The following is a description of a gene set: Reactome Pathway: Free fatty acid receptors studied in species Homo sapiens Fatty acids are the ligands for a small family of G-protein-coupled receptors, the Free Fatty Acid receptors, and an unrelated receptor GPR120. <br><br>Free fatty acid receptor 1 (FFAR1/GPR40) is activated by both saturated and unsaturated medium to long-chain fatty acids while FFAR2 (GPR43) and FFAR3 (GPR41) are activated by short-chain fatty acids (carboxylates) with six or fewer carbon molecules. A fourth highly homologous receptor GPR42 is believed to be a pseudogene with intact open reading frame, but could be a functional gene in a significant fraction of the human population. <br><br>GPR120 is activated by long chain (C16-22) fatty acids. part of: Class A/1 (Rhodopsin-like receptors), and this is the list of marker genes: FFAR4, FFAR2, FFAR1, GPR31, FFAR3